Given this list of marker genes Zfp354b (zinc finger protein 354B, NCBI Gene Id 27274), Slc27a4, Neurl1a, Dapk1, Mbd4, Tenm3, Asap2, Akap11, Ripk1, Slco3a1, Erc2, Btbd1, Cdsn, Flt4, Trpc1, Sgo1, Cacna2d3, Selenon, Zfp202, Dennd3, Mllt3, Tmem203, Mfsd13a, Hsd3b1 (hydroxy-delta-5-steroid dehydrogenase, 3 beta- and steroid delta-isomerase 1), Pcdhb16, Atp8b3, Trp53inp2, Rab8a, Psmf1, Abcb9, Pkp1, Tmem260, Tmem44, Cul5, Csn2, Trub2, Ube2g1, Rtf1, Ntng1, Dll1, Pla2r1, Kmt2a, Cpd, Asb1, Ptgdr2, Lsm14b, Hook1, Gabra3, Tbc1d32, Zfp91, Pfkp, Nek5, Nrg3 (neuregulin 3), Etv5, Zfp174, Slc5a3, Specc1, Ppp1r1b, Abce1, Stox2, Sulf1, Zbtb44, Tbl1xr1, Celf3, here is a description of the gene set: Genes predicted to be targets of miRBase v22 microRNA mmu_miR_871_3p in miRDB v6.0 with MirTarget v4 prediction scores > 80 (high confidence targets). Mouse Gene Set: MIR_871_3P from publication Chen Y, Wang X (PMID 31504780) species: Mus musculus